The following is a description of a gene set: from publication Burton GR, Nagarajan R, Peterson CA, McGehee RE Jr (PMID 15033539) studied in species Mus musculus Progressively down-regulated 8-96 h during differentiation of 3T3-L1 cells (fibroblast) into adipocytes. During cellular differentiation and development, it is recognized that many complex molecular mechanisms as well as precise patterns of differentially expressed genes occur in directing precursor cells toward a given lineage. Using microarray-based technology, we examined gene expression across the course of 3T3-L1 adipocyte differentiation. Total cellular RNA was isolated at times 0, 2, 8, 16, 24, 48, and 96 h following treatment with either standard hormonal inducers of differentiation; insulin, dexamethasone, isobutylmethylxanthine (IDX), or IDX plus trichostatin A (TsA), a histone deacetylase inhibitor and potent adipogenic inhibitor. cRNA was synthesized from cellular RNA and hybridized to high density Affymetrix MG_U74Av2 microarray gene chips containing 12,488 cDNA/Expressed Sequence Tags (ESTs) probe sets. From the IDX-only treated cells, all probe sets that were either unchanged or differentially expressed less than 2-fold throughout differentiation with respect to time 0 preadipocytes were excluded from further analyses. This selection resulted in a net of 1686 transcripts, 859 were increased in expression, and 827 were decreased in expression at least 2-fold across differentiation. To focus in on genes that were more specific to differentiation, the same analysis was performed on IDX plus TsA-treated non-differentiating cells and all probe sets from the IDX-only group that exhibited similar expression profiles in the non-differentiating TsA-treated group were excluded leaving a total of 1016 transcripts that were regulated only under differentiating conditions. Six hundred and thirty-six of these transcripts were elevated at least 2-fold and 380 exhibited a decrease in expression relative to time 0 preadipocytes. This group of genes was further analyzed using hierarchical clustering and self-organizing maps and resulted in the identification of numerous genes not previously known to be regulated during adipocyte differentiation. Many of these genes may well represent novel adipogenic mediators and markers of adipogenesis. Mouse Gene Set: BURTON_ADIPOGENESIS_8, and this is the list of marker genes: F2r, Twist2, Serpinf1, Vcl, Bax, Leprot (leptin receptor overlapping transcript), Capg, Emp1, Tceal9 (NCBI Gene Id 99775), Prss23, Slc1a4, Dstn, Plxnb2, Mapkapk2, Cd276, Zfp36l2, Cmtm3, Ctsa, Kdelr3, Tspan6, Prr13, Pla2g7, Psap, Rab7-ps1, App, Daxx, Sertad1, Tpbg, Anxa3, Gba1, Myh9, Gstm2, Tapbp, Anxa5, Emp3, Scpep1 (serine carboxypeptidase 1), Fgf7, Matn4, Smad6, Lamp2, Serpinb6a, Prdx4, Pld3, B9d1, Tmsb10, Asah1, Hmgcr, Fam91a1, Slc38a4, Lox, Tes (testin LIM domain protein), Ski (ski sarcoma viral oncogene homolog (avian)), Kctd10, Pdlim7, Nsa2, Pltp, Itgav, Rps6ka4, Rab31, Acta2, Gnb1, Ptgis, Msn, Ogn, Tuba1a, Sptan1, Pdpn, Cap1, Praf2 (NCBI Gene Id 97593), Gng10, Cpq, Ncam1, Usp22, Vcam1, Col4a5, Slc7a5, Bdnf, Phldb2, Fxyd5, Map1lc3b